Given this list of marker genes DLG1, ENTPD4, NUDT18, MAGI3, DLG2, TJP2, GUK1, CASK, CARD11, MPP1, LRGUK, here is a description of the gene set: The chemical reactions and pathways involving GDP, guanosine 5'-diphosphate. Human Gene Set: GOBP_GDP_METABOLIC_PROCESS studied in species Homo sapiens